The following is a description of a gene set: species: Homo sapiens Tumor-specific translocations are common in tumors of mesenchymal origin. Whether the translocation determines the phenotype, or vice versa, is debatable. Ewing's family tumors (EFT) are consistently associated with an EWS-FLI1 translocation and a primitive neural phenotype. Histogenesis and classification are therefore uncertain. To test whether EWS-FLI1 fusion gene expression is responsible for the primitive neuroectodermal phenotype of EFT, we established a tetracycline-inducible EWS-FLI1 expression system in a rhabdomyosarcoma cell line RD. Cell morphology changed after EWS-FLI1 expression, resembling cultured EFT cells. Xenografts showed typical EFT features, distinct from tumors formed by parental RD. Neuron-specific microtubule gene MAPT, parasympathetic marker cholecystokinin, and epithelial marker keratin 18 were up-regulated. Conversely, myogenesis was diminished. Comparison of the up-regulated genes in RD-EF with the Ewing's signature genes identified important EWS-FLI1 downstream genes, many involved in neural crest differentiation. These results were validated by real-time reverse transcription-PCR analysis and RNA interference technology using small interfering RNA against EWS-FLI1 breakpoint. The present study shows that the neural phenotype of Ewing's tumors is attributable to the EWS-FLI1 expression and the resultant phenotype resembles developing neural crest. Such tumors have a limited neural phenotype regardless of tissue of origin. These findings challenge traditional views of histogenesis and tumor origin. from publication Hu-Lieskovan S, Zhang J, Wu L, Shimada H, Schofield DE, Triche TJ (PMID 15930281) Genes up-regulated in RD-EF cells (rhabdomyosarcoma) engineered to express EWSR1-FLI1 fusion and which are also highly expressed in Ewing's famliy tumors. Human Gene Set: ZHANG_TARGETS_OF_EWSR1_FLI1_FUSION, and this is the list of marker genes: G0S2, HOXD9 (NCBI Gene Id 3235), CCK, LY96, CITED2, GYG2, IPO13, SH2B3, SYT1, MYO10, WDR47, CSRP1, FOS, STEAP1, ARHGEF1, SORD, MAN2A2, HES1, SIRPA, XPNPEP1, GLG1, ZDHHC3, ME1, SLC17A7, NPTXR, RHOH, GUSBP14, GRK5, CSNK1E, CD99P1, CDH11, STAT6, GLCE, ATF5, WNT5A, ATP1A1, NELL2, HLA-E, DAPK1, GPSM3, CDK14 (NCBI Gene Id 5218), DPYSL2 (NCBI Gene Id 1808), CAV2, PFKP, OLFM1, IGFBP4, FCGRT, PSEN1, CCND1, CHN2, STARD13, MAPT, RAP1GAP, KYAT1, SMARCC1, UBXN7, AK4, PPFIA3, FADS1, GABARAPL1, VWA5A, RCOR1, ST6GAL1, SLC1A4, GUSBP3, JAK1, CSPG5, RNF113A, RUNX3, SEL1L3, UAP1, CAV1, FNBP1, CD99, CD79A (CD79a molecule), CEBPB, EGR2, MYC, CES1, CD1E, PRKCB, IL1RAP, IFITM1, TRIM2, MSX1, CRIP2, ID2, KDSR, ADO, HIPK1